The following is a description of a gene set: Factors that drive prostate cancer progression remain poorly defined, thus hindering the development of new therapeutic strategies. Disseminated tumors are treated through regimens that ablate androgen signaling, as prostate cancer cells require androgen for growth and survival. However, recurrent, incurable tumors that have bypassed the androgen requirement ultimately arise. This study reveals that the Brm ATPase, a component of selected SWI/SNF complexes, has significant antiproliferative functions in the prostate that protect against these transitions. First, we show that targeted ablation of Brm is causative for the development of prostatic hyperplasia in mice. Second, in vivo challenge revealed that Brm-/- epithelia acquire the capacity for lobe-specific, castration-resistant cellular proliferation. Third, investigation of human specimens revealed that Brm mRNA and protein levels are attenuated in prostate cancer. Fourth, Brm down-regulation was associated with an increased proliferative index, consistent with the mouse model. Lastly, gene expression profiling showed that Brm loss alters factors upstream of E2F1; this was confirmed in murine models, wherein Brm loss induced E2F1 deregulation in a tissue-specific manner. Combined, these data identify Brm as a major effector of serum androgen-induced proliferation in the prostate that is disrupted in human disease, and indicate that loss of Brm confers a proliferative advantage in prostate cancer. from publication Shen H, Powers N, Saini N, Comstock CE, Sharma A, Weaver K, Revelo MP, Gerald W, Williams E, Jessen WJ, Aronow BJ, Rosson G, Weissman B, Muchardt C, Yaniv M, Knudsen KE (PMID 19074882) species: Homo sapiens Genes whose expression negatively correlated with that of SMARCA2 in prostate cancer samples. Human Gene Set: SHEN_SMARCA2_TARGETS_DN, and this is the list of marker genes: BMP10, INE1, FSHB, CYP2A6, CBL, CRYGB, GABRA1, PIAS1, PREX2, ENSG00000235059, TP53TG5, CPSF1, CLCN1, ACTL8, CLCNKA (NCBI Gene Id 1187), SOCS7, DSCAM, NPY2R, CCL16, FGF23, ASIC4, TTTY2, PBX3-DT, KLHDC8A, COA7 (cytochrome c oxidase assembly factor 7), TCL6, PRDM14, ALDOB, LTA, MYH13, ADGRE3, AQP8, REEP2, ANO2, GABRD, TAS2R16, FAM153A, NOX5, IFNA4, TNFSF8, B3GNT4, C6orf15, IL18BP, FASLG, RHBDD3 (rhomboid domain containing 3, NCBI Gene Id 25807), MC2R, RNASE2CP, GABRR2, VDR, DNAJA1P4, TNR, ADRA2B, MYBL2, GDF5, LIPC, CRCP, TBX6, APOBEC1, DAO, GPR75, TREM1, CLCF1, ALDH3B1, E2F4, IL1RN, NOCT, AMHR2, NR0B2, TNF, CYP11A1, PTCRA, NECTIN1, AIPL1, PADI1, MEPE, DGCR5, CAMKV, LILRA1, COL11A2, UPK2, KCNJ10, AQP5, ICOSLG, GABBR2, MMP19, E2F1, AQP6, EFNB3, C3, HTR6, PDE6A, CPNE7, FLRT1, ETV3, ADD2, FOLR1, INKA2, CNTN2, SIGLEC7, PDGFB, FUT3, SNAI1 (NCBI Gene Id 6615), PAX4, USH1C, CYP11B2, SMR3B, PRORY, CACNG3, EGR4, DPF1, NHLH1, PRX, IKBKE, PROP1, CD82, GLRA1 (glycine receptor alpha 1), ALPP, ESPL1, NLRP3, TAS2R1, DIAPH1, FGA, TRGV3, PDE6G, KIR2DS3, CHRM5, MIER2, CA12, TLR6 (toll like receptor 6), GRK2, VRTN, SULT1B1, FOXA2, GPR12, ALLC, LILRB3, KIR3DL3, CHRND, SPTB, OR3A3, CENPI (NCBI Gene Id 2491), TG, CCNF, SLC1A7 (NCBI Gene Id 94490), CCKAR, PRSS3P3, PHF24, MAGEA10, HYAL4, TSHZ2, TROAP, CEACAM3, SLC28A1, BPY2, SPANXA1, OR7C2, SCN2A, G6PC2, CNGB3, BCAN, SLC7A10, CYP3A4, CENPA, IL11 (interleukin 11), WNT10B, PAX5, DRD2, DLX4, EDIL3-DT, HLA-DOA, BMP1, FABP7, CYP2D6, CSNK1D, CYTH4, LINC02809, DDN, CATSPERZ, BMP7, FGF1, MAT1A, CHRM2, IVL, GPR21, ATXN8OS (ATXN8 opposite strand lncRNA), GCM1 (NCBI Gene Id 8521), C15orf39, ACR (acrosin), TLX1, CDK5R1, MTMR8, HSF2BP, SEPTIN4, AP4S1, EPX, KIR3DL2, TF, GYPA, ENOX2, CIBAR1, PPP1R14D, RSPH6A, DPPA4, RBPJL, S1PR4, ADAM5, GJD2, LINC00652, LINC01711, HOXB5, CYP17A1, RHO, SLC1A2, CAMK2A, FBXO31, KRT85, GCNT4, CFP, BTNL3, CYP21A2, TM4SF5, TNFAIP2, MAP3K19, SOX21, SMAD5-AS1, SEMA6B, RAB3IL1, SLC24A2, PLEK, NR6A1, CCNK, OR1D2, ERN2, IRF4, CA9, PSORS1C2, KMO, USP29 (NCBI Gene Id 57663), CDH18, LBP, GHRHR, ALAS2, CCZ1, CD22, MIR124-1HG, SPTBN5, GJA8, ARSF, TEX13B, CHST12, RUNX2, KCNJ4 (NCBI Gene Id 3761), GNRH2, CALB2, MYT1, DCT, RGR, GLP1R, NFATC1, HTR4, ENDOU, TYR, NPHP1, NNAT, FGB, CYP2C9, BIRC5, PRDM16, PVT1, PDPK1, ADD3-AS1, BTG2-DT, HK2-DT, FUT2, ADCY6, MAP1A, POU2F2, CA7, SLC6A13, SSX3, GPR3, SCN4A, LZTS1, WNT8B, CCNT1, CAMK2B, KHSRP, IL36A, TCP10L3, PADI4, RPL13P5, SLC14A2, TMPRSS15, OSBP2, FBLN1, KALRN, TSPY2, SIT1, CCDC9, NOX1, GABRG2, CHRNA3, ABCC2, TRMT61A (NCBI Gene Id 414769), GNL3L, GPR31, RUNDC3A, SOX10, XPNPEP2, RUNX1, KCNK10, IGHE, PAPOLG, ATP10B, TEX15, NPPA, LILRA4, GOLGA2 (NCBI Gene Id 2801), OPRM1, AMBN, CTXND1